Given this list of marker genes Lrrc27, Usp31, Ptbp2, Ezh2, Wipf3, Tasl (TLR adaptor interacting with endolysosomal SLC15A4), Fbxo10, Tfdp1, Brox, Ube3c, Alpk3, Trim26, Kcna6, Cbln3, Klc4, Pglyrp4, Zfx, Rimkla, Ccnd3, Garre1, Rbm8a, Tceanc2, Erf (NCBI Gene Id 13875), Yaf2, Tmem161b, Mpc1, Parp16, Ube2q1, Camsap2, Fermt2, Lrp1, Diaph1, Fabp3, Jph1, Nrf1, Gdpd2, Kdm3b, Aak1, Josd2, Epha4, Mov10, Klhl5, Rab1b, Tenm4, Hs3st3b1, Mtfr1l, Vat1, Edem3, Sema6d, Prkaa2, Dnmbp, Tent4b, Nexmif, Zyx, Mex3c, Mycbp, Nr6a1, Tmbim6, Dpysl2, Smg6 (NCBI Gene Id 216951), Ubr5, Erbb4, Polr2a, Zfp551, Fkbp1a, Gls, Macf1, Dip2b, Ajuba, Gfer, Snx12, Zscan29, Il13ra1 (NCBI Gene Id 16164), Map3k9, Celf6, Sptbn4, Rgs9, Rap1gap2, Zmym3, Slc35d1, Rock1, Pakap, Nhs, Tagln3, Gins3, Znrf3, Cd74, Chmp1a, Sdcbp, Rab3c, Fnbp1l, Cnst, Pgrmc2, Crkl, Fntb, Scd1, Slc4a7, Raver2, Map3k11, Fbxw8, Pptc7, Grpel1, Papss2, Sec61a2, Prtg, Pitpnm3, Crtac1, Bcl2l11, Lrrc19, here is a description of the gene set: from publication Chen Y, Wang X (PMID 31504780) species: Mus musculus Mouse Gene Set: MIR_6939_5P Genes predicted to be targets of miRBase v22 microRNA mmu_miR_6939_5p in miRDB v6.0 with MirTarget v4 prediction scores > 80 (high confidence targets).